Given this list of marker genes FBXL20, SV2C, RIMS4, ATP2A2, RIMS1, SLC4A8, SYT5 (NCBI Gene Id 6861), SYT2, VPS18, FBXO45, SEPTIN5, RAP1BL, CSPG5, SYT13, NPY, FMR1, PPFIA2, RIMS2, RIMS3, GPR151, CASK, GIT1, PFN2, SV2B, RAB3GAP1, RAP1B, PRKCB, SYT4, P2RY1, P2RX1, STXBP5 (NCBI Gene Id 134957), SYT8, SNAPIN, PREPL, LRRK2, SYT1, RAB3A, CALM3, CACNA1B, PRKCG, WNT7A, CACNB4, PPP3CA, SYN1, BRAF, CDK5, NLGN1, RAB5A, DTNBP1, RAP1A, DVL1, here is a description of the gene set: species: Homo sapiens Human Gene Set: GOBP_REGULATION_OF_SYNAPTIC_VESICLE_EXOCYTOSIS Any process that modulates the frequency, rate or extent of synaptic vesicle exocytosis.